The following is a description of a gene set: studied in species Mus musculus The formation of adhesions that stabilize protrusions at the leading edge of a migrating cell; involves integrin activation, clustering, and the recruitment of structural and signaling components to nascent adhesions. Mouse Gene Set: GOBP_SUBSTRATE_DEPENDENT_CELL_MIGRATION_CELL_ATTACHMENT_TO_SUBSTRATE, and this is the list of marker genes: Epb41l5 (NCBI Gene Id 98492), Stk4, Fn1, Fbln1, Tnfrsf12a, Spag6l